Given this list of marker genes Fabp1, Fabp7, Fabp6, Pnpla5, Fabp3, Fabp12, Fabp4, Fabp2, Fabp9, Fabp5, Gpd2, here is a description of the gene set: studied in species Mus musculus Triglyceride catabolism Mouse Gene Set: REACTOME_TRIGLYCERIDE_CATABOLISM